Given this list of marker genes DUOX2, APP, ITGB2, CYBA, NCF1B, RAC1, CYBB, SLC1A1, BST1, ITGAM, ACP5, SOD3, ALOX12, DHFRP1, SH3PXD2B, NCF2, RAC2, SH3PXD2A, TYROBP, CYGB, CD36, SOD2, NCF4, TGFB1, PRKCE (NCBI Gene Id 5581), NOX4, ELAVL1, NOX3, EDN1, NAGLU, BMP7, IMMP2L, NCF1, NRROS, MB, CLEC7A, CYB5R4, MAPT, NCF1C, GSTP1, NOS2, DHFR, CRP, CD177, CCS, NOX1, PARK7, PRG3, GNAI2, MT3, PRDX1, ATP7A, PRKCD, NFE2L2, SHC1 (NCBI Gene Id 6464), PON3, ENSG00000274276, FPR2, AGT, NQO1, PREX1, NOXO1, APOA4, MPO, SOD1, NOX5, CBS, NOXA1, NOS3, MIR27B, PRDX2, FBLN5, SYK, GCH1, TAFA4, F2RL1, DUOX1, here is a description of the gene set: Human Gene Set: GOBP_SUPEROXIDE_METABOLIC_PROCESS The chemical reactions and pathways involving superoxide, the superoxide anion O2- (superoxide free radical), or any compound containing this species. studied in species Homo sapiens